Given this list of marker genes PSME3IP1, CDC6, GCLM, PSMB3, CPN1, NBEAL2, LAPTM5, CELSR1, PTTG1 (PTTG1 regulator of sister chromatid separation, securin), CST7, GADD45A, NAA38, GEMIN5, ITM2C, MKI67, SURF4, ASPM, CYTH3, BAIAP2, DYNLRB1, TSC22D1, PRC1, CD27, NR2C2, SAR1B, CHCHD10, STMN1, SFMBT2, TNFSF11, SSBP2, RANBP1, ASF1B (anti-silencing function 1B histone chaperone), SMC4, ZAP70, RAB3IP, BLM, TMEM38B, PRKACB, RPA1, THOC7, NOCT, CNDP2, DTYMK, SSX2IP, KIF23, CDK1, RPS14, POLA1, PSMB9, CDC42SE1, UNC119B, R3HCC1, TXK, AP3S1, ANGPTL2, SNHG6, ANLN, CAPN3, DBI, ARHGAP9, PSMB6, MCM7 (minichromosome maintenance complex component 7), GJB2, EVL, GMFB, CD160, LAG3, RFLNB, POMP, MRPL41, MEMO1, SGK1, MYO1F (myosin IF), PFKP, PSMA4, PDK1, CDC45, IGF2R, HPCAL1, YARS1, EBP, ELAVL1, NRGN, SEPTIN9, MRTO4, CD3D, PCLAF, IDI1, ATP5IF1, MX1, PPIC, PSAT1, ITGAL, BRK1, CENPK, GTF2I, XDH, IMPA2, SOAT2, TRIM59, GALK1, WRN, ITPKB, ACIN1, GSN, LCK, RFC5, ACTN2, CCL5, ARL4C, LCP1, BIRC5, RGS10, DRC1 (dynein regulatory complex subunit 1), GATD3, SELPLG, BCL2, ARF1, KLRK1 (killer cell lectin like receptor K1), NUDT1, DHRS4, CDCA5, ACP6, SPRED2, CKS2, RANBP3, DAD1, BCL2L11, RAB8B, PELI1, VPS26B, NOTCH1, MPHOSPH9, CD28, PPM1B, YJU2, ADH1C, USP3, PRKCQ, MEIG1, MCM2, STK19, H2AX, EMB, PTPRCAP, PHF5A, CIP2A, EZH2, PKP4, CAPNS1, SARAF (store-operated calcium entry associated regulatory factor), UCK2, KIN, KLRD1, LCP2, STK39, HAUS3, FRAT1 (FRAT regulator of WNT signaling pathway 1), CTSD, TOP2A, ROM1, RAB8A, POLR2D, DNMT1, ITK, GFI1, ADGRL1, SSRP1, POLD2, SLC12A7, PDE9A, DLX3, FRAT2, TNFRSF9, TFPI, SASS6, CD3G, KLHDC4, LMNB1, ID2, TTK, THY1, PRIM1, PTPN13, NAA11, EIPR1, TCF7, NCAPH, GABARAPL1, RNF149, TNFRSF18 (TNF receptor superfamily member 18), LAMTOR4, FADS1, ST3GAL4, NSG2, ID3, GALNT2, FGF9, DHFR, MRPS28, here is a description of the gene set: from publication Walker LJ, Kang YH, Smith MO, Tharmalingham H, Ramamurthy N, Fleming VM, Sahgal N, Leslie A, Oo Y, Geremia A, Scriba TJ, Hanekom WA, Lauer GM, Lantz O, Adams DH, Powrie F, Barnes E, Klenerman P (PMID 22086415) species: Homo sapiens Genes down-regulated in KLRB1 high T cells: CD8A versus CD8A CD8B. This SuperSeries is composed of the SubSeries listed below. Human Gene Set: GSE33425_CD8_ALPHAALPHA_VS_ALPHABETA_CD161_HIGH_TCELL_DN